Given this list of marker genes GTPBP4, HCFC1, SNW1, RUVBL1, SAP18, MAP7, GPBP1, RRP1B, RAVER1, PNN, DCAF13, BRD2, CHD8, RBM33, H2AC1, DIDO1, TPX2, YY1, JRK, INO80, LMO7 (LIM domain 7), NUSAP1, here is a description of the gene set: Proteins associated with ZNF143 in HeLa cells, based on MudPIT analysis. species: Homo sapiens Human Gene Set: YUAN_ZNF143_PARTNERS Chromatin remodeling and histone modification are essential for eukaryotic transcription regulation, but little is known about chromatin-modifying activities acting on RNA polymerase III (Pol III)-transcribed genes. The human U6 small nuclear RNA promoter, located 5' of the transcription start site, consists of a core region directing basal transcription and an activating region that recruits the transcription factors Oct-1 and Staf (ZNF143). Oct-1 activates transcription in part by helping recruit core binding factors, but nothing is known about the mechanisms of transcription activation by Staf. We show that Staf activates U6 transcription from a preassembled chromatin template in vitro and associates with several proteins linked to chromatin modification, among them chromodomain-helicase-DNA binding protein 8 (CHD8). CHD8 binds to histone H3 di- and trimethylated on lysine 4. It resides on the human U6 promoter as well as the mRNA IRF3 promoter in vivo and contributes to efficient transcription from both these promoters. Thus, Pol III transcription from type 3 promoters uses some of the same factors used for chromatin remodeling at Pol II promoters. from publication Yuan CC, Zhao X, Florens L, Swanson SK, Washburn MP, Hernandez N (PMID 17938208)